Given this list of marker genes PROC (NCBI Gene Id 5624), GP1BA, GP9, F11 (coagulation factor XI), VWF, SERPIND1, SERPINE2, GP1BB, F9, PROS1, F5, F10, SERPINA5, GP5, SERPINC1, ANO6, F8, F2, here is a description of the gene set: species: Homo sapiens The amplification and propagation phases of coagulation are characterized by the production of large amounts of activated coagulation factors, accompanied by platelet activation. This leads to a substantial burst of thrombin generation on the surfaces of platelet membranes.<p>During the amplification phase, a small amount of thrombin (FIIa) produced during the tissue factor (TF)-mediated initiation phase facilitates further coagulation. On the platelet surface, thrombin activates coagulation factors XI (FXI), VIII (FVIII), and V (FV). Activated FXI (FXIa) converts factor IX (FIX) into its active form (FIXa), which then associates with the cofactor FVIIIa. The resulting FIXa:FVIIIa complex, known as the tenase complex, activates factor X (FX) to FXa. FXa subsequently binds to FVa, forming the FXa:FVa complex, also called prothrombinase. The prothrombinase complex converts prothrombin to thrombin, which in turn cleaves and activates additional FXI, FVIII, and FV, creating positive feedback loops (O'Donnell JS et al., 2019; Preston RJS et al., 2019).<p>Thrombin also interacts with platelet surface receptors, such as protease-activated receptors (PARs), contributing to platelet activation, degranulation, and the recruitment of additional platelets to the injury site. Activated platelets aggregate, forming a platelet plug (Swieringa F et al., 2018; Sang Y et al., 2021). Procoagulant platelets further release clotting factors and expose phosphatidylserine (PS) on their cell membranes, providing surfaces for coagulation factors and promoting the assembly of the tenase (FIXa:FVIIIa) and prothrombinase (FXa:FVa) complexes (Lentz BR 2003; Swieringa F et al., 2018; Sang Y et al., 2021; Majumder R 2022). This generates large amounts of thrombin through FXa:FVa-catalyzed two-site cleavage of prothrombin (FII). While thrombin generation primarily occurs on the surfaces of activated platelets, other PS-bearing cells, such as leukocytes and endothelial cells, may also contribute (Zhang Y et al., 2016; Tong D et al., 2018).<p>Thrombin produced during the amplification and propagation phases converts soluble fibrinogen into fibrin monomers, which polymerize to form insoluble fibrin fibers. Thrombin also activates FXIIIa, which cross-links fibrin fibers, stabilizing the thrombus. Reactome Pathway: Amplification and propagation of coagulation cascade part of: Coagulation pathway